The following is a description of a gene set: electronically inferred by orthology from the curated human pathway species: Mus musculus Reactome Pathway: Aerobic respiration and respiratory electron transport This event has been computationally inferred from an event that has been demonstrated in another species.<p>The inference is based on the homology mapping from PANTHER. Briefly, reactions for which all involved PhysicalEntities (in input, output and catalyst) have a mapped orthologue/paralogue (for complexes at least 75% of components must have a mapping) are inferred to the other species. part of: Metabolism, and this is the list of marker genes: Tmem126b, Uqcrfs1, Sdhb, Ndufv2, Pkm, Cox17, Coa5, Got2, Sirt4, Pdk2, Atp5f1b, Ndufa9, Mrps36, Gid4, Dmac2l, Ndufc1, Lyrm4, Coq10a, Cox7a1, Dlst, Fh1, Ucp2, Pdha1, Higd2a, Higd1c, Ndufb8, Uqcr10, Ldhal6b, Atp5po, Ndufs8, Ndufaf1, Isca1, Fahd1, Ndufb3, Ndufa12, Ubb, Sdhaf1, Got1, Iscu, Ndufb10, Gpt, Vdac1, Cycs, Trap1, Atp5pf, Ndufa5, mt-Nd6, D2hgdh, Ndufaf4, Ndufa2, Atp5mc2, Cyc1, Ndufaf7, Cox4i1 (cytochrome c oxidase subunit 4I1), Cox8c, Cox5a, Ranbp9, mt-Nd3, Cox6a2, Slc25a11, Ndufa13, Ndufb9, Ndufs6, Ldhb, Uqcrc2 (ubiquinol cytochrome c reductase core protein 2), Pdp1, Ndufa7, mt-Cytb, Pdpr, Tmem177, Ldhc, Pgam5 (phosphoglycerate mutase family member 5), Atp5mk, Slc25a22, Ndufv3, L2hgdh, Cox11, Ecsit, Slc25a14, Ucp1, Ndufaf3, Cox7a2l, Ucp3, Ndufs7, Ndufs3, Cox8a, Dld, Idh3g, Gstz1, Ndufb1, Slc25a13, Uqcr11, Rps27a, Fxn, Dlat, Ndufa10, Slc25a4, Ndufa4, Sdhaf2 (NCBI Gene Id 66072), Sdhaf3, Cox14, Ndufs5, Idh2, mt-Atp8, Armc8, Ndufaf6, Slc25a18, Cox18, Atp5pd, Pdk4, Atp5mc1, Nubpl, Cox6c, Rmnd5b, Pyurf, Sco2, Ndufaf5, Cox6a1, Cox7c, Hccs, Cox4i2, Cox20, Ldha, Mdh2